Given this list of marker genes KLHL22, YWHAG, MR1, HSPD1, HLA-DRB1, HLA-DRB3, FBXO38, SLC22A13, PRKAA1, here is a description of the gene set: Human Gene Set: GOBP_POSITIVE_REGULATION_OF_T_CELL_MEDIATED_IMMUNE_RESPONSE_TO_TUMOR_CELL Any process that activates or increases the frequency, rate, or extent of a T cell mediated immune response to tumor cell. species: Homo sapiens